The following is a description of a gene set: Genes upregulated in subsets of cells of a given type within various tumors species: Homo sapiens Human Gene Set: GAVISH_3CA_METAPROGRAM_EPITHELIAL_EPISEN from publication Gavish A, Tyler M, Greenwald AC, Hoefflin R, Simkin D, Tschernichovsky R, Galili Darnell N, Somech E, Barbolin C, Antman T, Kovarsky D, Barrett T, Gonzalez Castro LN, Halder D, Chanoch-Myers R, Laffy J, Mints M, Wider A, Tal R, Spitzer A, Hara T, Raitses-Gurevich M, Stossel C, Golan T, Tirosh A, Suvà ML, Puram SV, Tirosh I (PMID 37258682) In this study, an extensive analysis was conducted to define meta-programs (MPs) capturing intra-tumor heterogeneity across a spectrum of tumor types. The approach utilized non-negative matrix factorization (NMF) to analyze each cell type separately within individual tumor samples. This involved the analysis of malignant cells, macrophages, fibroblasts, endothelial cells, epithelial cells, T-cells, and B-cells. NMF was executed with varying parameter values (K=4, 5, 6, 7, 8, 9), thereby generating 39 programs for each cell type per sample. Each NMF program was summarized by the top genes based on NMF coefficients.\nRobust MPs were then delineated for each cell type using a set of stringent criteria, including recurrence within the same tumor, similarity to programs in other tumors, and non-redundancy within a tumor. Subsequently, these robust NMF programs were clustered (per cell type) based on Jaccard similarity, leading to the identification of MPs associated with each cell type.\nTo enhance the quality of the MPs, a refinement steps were undertaken, involving the removal of MPs suspected of reflecting low-quality data (with an overrepresentation of ribosomal proteins or mitochondrial-encoded genes), single-study inclusion, or similarity to miss-annotated cell types., and this is the list of marker genes: KRT10, LY6D, CRABP2, AQP3, SERPINB1, KRT6A (keratin 6A), CSTA, GLTP, RAB25, KRT13, CD24, LYPD3, SULT2B1, PDZK1IP1, IL1RN, KRTDAP, KRT4, S100A9, SLPI, S100A8, KLK11, CALML3, GJB2, DSC2, AKR1B10, SBSN (suprabasin), KRT16, KRT6B, FABP5, TMEM45A, SPRR1B, SPINK5, SERPINB4, CLIC3 (chloride intracellular channel 3), SERPINB3, PKP1, SERPINB13 (serpin family B member 13), MAL2, KRT1 (keratin 1), TMEM40, CLDN4, DMKN, RHCG, CALML5, SPRR1A, IVL, S100A7, CSTB, GPR15LG, KRT6C